Given this list of marker genes SMARCA4, SPDL1, CLASP1, TRIP13, FBXO5, CDC20, MAP10, KNL1, MAPK15, DCTN2, CDC27, ANKRD53, PTTG3P, MCMDC2, SYCE2, TPR, ANKRD31, SEH1L, ASPM, DRG1, AKAP8L, SPATA22, ANAPC4, RCC1, CENPE, ACTR3, MAPRE1, WRAP73, KIF18A, CCDC66, TEX12, BCCIP, KIF11, PDCD6IP, BUB1B, SKA1, POLDIP2, AKAP8 (NCBI Gene Id 10270), RCC2, PINX1, ABRAXAS1, PLK1, FANCD2, RMI2, BECN1, DPF1, M1AP, CHMP1A, PRP4K, KIF2B, MLH1, CHAMP1, MAP9, OFD1, BCL7C, CCNB2, ANAPC11 (anaphase promoting complex subunit 11), CDCA5, KAT2B, FAM83D, ACTL6B, RNF212, ANAPC15, CHMP6 (charged multivesicular body protein 6), KIF3B, WASHC5, PRC1, CDCA8, DUSP1, BUB1, MLH3, CHMP2A, SPC25, CHMP5, C14orf39, PSMG2, UBE2B, SMARCA5, NUP62, EML4, KIF15, NSMCE2, TEX15, SPC24, HORMAD1, DPF2, BUB3, LCMT1, MAEL, BAZ1B, FLNA, RAB24, SMARCE1, PSRC1, RIOK2, SYCE3, NCAPH2, CDC16, TERF1, NDC80, ANAPC7, ANAPC5, TTL, MAP3K20, CHMP2B, ESPL1, ECT2, PRDM9 (PR/SET domain 9), MIS12, IHO1, ANAPC1, NCAPD2 (NCBI Gene Id 9918), AGO4, MAP1S, CEP192, ZNF207, BAG6, DMC1, CENPQ, ZWILCH, RRS1, MRE11, SYCE1L, SMC2, SUN1, ZW10, SKA2, CENPI, CHMP7, PHF10, STAG3, KIF2C, EHMT2, APC, CHMP4B, UHRF1, MSH5, NCAPD3, KNTC1, TENT4A, ARID1B, TERB1, KIF23, GEN1, BIRC5, TUBG1, DPF3, SMC1A, NUDC, VPS4B, CHEK2, AURKC, SMARCB1, BRIP1, SYCP2, NEK6, CDK5RAP2, SPDYA, DYNC1H1, PTTG1, RIPOR2, ACTR2, UBE2C, CHMP3, TPX2, ABRAXAS2, CHFR, KPNB1, MAD1L1, INCENP, PIBF1, ACTL6A, TERB2 (telomere repeat binding bouquet formation protein 2), SMARCD2, SIRT7 (sirtuin 7), CUL3, CENPC, MZT1, DSN1, TRAPPC12, KIF22, MEIKIN, GOLGA2 (golgin A2), STAG2, BCL7B, RB1, CENPK, SHOC1, DIS3L2, CCNB1IP1, BRD7, CHMP4BP1, PTTG2, KATNB1, CENPF (NCBI Gene Id 51468), TTK, CEP97 (NCBI Gene Id 79598), NIPBL, PRICKLE1, LSM14A, ARHGEF10, CEP55, WAPL, CCNE1, KIFC1, C1orf146, XRCC3, SYCE1, NDC1, AURKB, ZCWPW1, DYNC1LI1, REC8, P3H4, INO80, MSH4, MND1, PMF1, HNRNPU, PSMC3IP, CDK1, TTN, KLHDC8B, SMARCA2, SIRT1, SPICE1, HSPA1A, H2BW1, KIF4A, RMDN1, NUSAP1, SMARCC1, SIRT2, CHMP1B, RNF212B, ANAPC2, CHMP4C, KAT5, KIF25, SPO11, KIF14, KASH5, NSL1, MAJIN, SKA3, HECW2, KLHL22, TOP2B, TEX11, ARID1A, SMARCC2, MAD2L2, NEK2, MAD2L1, MISP, VPS4A, NCAPG, TUBB8, MEI4, STAG1, ACTB, MEIOC, PPP2R1A, MEIOB, DDB1, CLASP2, CCSAP, C9orf78 (NCBI Gene Id 51759), PRAP1, AURKA, TUBG2 (tubulin gamma 2), MYBL2, PPP1CC, NUMA1, RACGAP1, NUF2, CDC42, SPAG5, SEPTIN1, HSPA1B, USP44, CCNE2, MAD2L1BP, PTEN, GEM, PHF13, MOS, SMC4, KIF2A, CDC6, TEX14, BCL7A, PBRM1, DLGAP5, CHMP4A, EML3, TOP2A, FMN2, NCAPH, IK, RHOA, CDT1, RANGRF, HASPIN, KNSTRN, SGO1, RAN, ATM, CCDC61, ZWINT, CCNB1, LATS1, RAD21, KIF18B, DCAF13, SYCP1, KMT5A, NCAPG2, SMARCD1, SMC3, ARID2, SMARCD3, KIF4B, RAB11A, CDC23, TACC3, BOD1, AAAS, here is a description of the gene set: studied in species Homo sapiens The process in which genetic material, in the form of nuclear chromosomes, is organized into specific structures and then physically separated and apportioned to two or more sets. Nuclear chromosome segregation begins with the condensation of chromosomes, includes chromosome separation, and ends when chromosomes have completed movement to the spindle poles. Human Gene Set: GOBP_NUCLEAR_CHROMOSOME_SEGREGATION